Given this list of marker genes Met, Pde4dip, Tubgcp2, Cav1, Mecp2, Arhgef7, Arl2, Mapt, Sgk1, Clasp1, Tppp, Slain2, Fkbp4, Ndel1, Ankrd53, Ccdc57, Camsap1, Drg1, Tbcd, Dyrk1a, Prune1, Map1b, Cep192, Tppp2 (tubulin polymerization-promoting protein family member 2), Diaph3, Rac1, Clip3, Git1, Numa1, Eml2, Nin, Nav3, Map2, Csnk1d, Nme7, Zfp207, Stmn2, Fes, Akap9, Nedd1, Tppp3, Slc39a12, Mzt1, Rp1, Tubgcp4, Camsap2, Clip1, Fgf13, Cdk5rap2, Hspa1a (NCBI Gene Id 193740), Abl1, Cenpj, Slain1, Tubg1, Fbxo5, Mapre3, Cav3, Tubgcp3, Camsap3, Tubgcp5, Tubb4a, Psrc1, Tubg2, Map7d3, Nde1, Snca, Tubb1, Pcnt, Cdh5, Gba2, Ssna1, Pak1, Rps3, Inpp5j (inositol polyphosphate 5-phosphatase J, NCBI Gene Id 170835), Ckap5, Tubgcp6, Mapk8, Apc, Dctn1, Tuba1a, Hdgfl3, Stmn1, Hspa1b, Haus2, Gda, Mapre1, Trpv4, Cdkn1b, Tpx2, Ccdc66, Map4, Kif21a, Wdr72, Clasp2, Golga2, Togaram1, here is a description of the gene set: The addition of tubulin heterodimers to one or both ends of a microtubule. species: Mus musculus Mouse Gene Set: GOBP_MICROTUBULE_POLYMERIZATION